The following is a description of a gene set: Genes up-regulated in comparison of primary splenic B cells from wild type mice versus those from BTK knockout mice. species: Homo sapiens Bruton's tyrosine kinase (Btk) is important for B lymphocyte development. To identify genes that are differentially expressed in primary B cells lacking functional Btk, splenocytes from X-linked immunodeficiency (Xid), Btk knockout (KO) and immunocompetent CBA mice, were used in microarrays containing more than genes and expressed sequence tags (ESTs). We found 4515 transcripts expressed in duplicate experiments in all three strains. Out of these, 38 were differentially expressed genes (21 up-regulated >2 fold and 17 down-regulated <-2 fold) between CBA and Btk defective mice. Ten out of these genes were selected and quantitative Real-Time PCR was conducted for validation and further investigation. Real-Time experiments correlated nicely with the microarray data. No definitive phenotypic difference has previously been reported between Xid and Btk KO mice. We found genes, whose expression differed (>2 fold) between the two strains. Moreover, when the genes, which differed between immunocompetent CBA and Btk defective mice were ranked according to fold-increase, the levels in Btk KO mice were significantly more altered. This suggests that the defect in Btk KO mice is more severe and demonstrates that the mutant Btk protein in Xid mice does not generally function as dominant negative form. Human Gene Set: GSE2826_WT_VS_BTK_KO_BCELL_UP from publication Lindvall JM, Blomberg KE, Berglöf A, Yang Q, Smith CI, Islam TC (PMID 15214046), and this is the list of marker genes: RNASEH2A, RIDA, SURF6, UBL3, PLSCR1, PHKG2, EVI2A, WDR6, SRPK3, ACY1, ENDOU, CXCR5, IMP3, CRY2, PRRC2A, PRIM1, RTCB, HERPUD1, ID3, EBI3 (Epstein-Barr virus induced 3), OAT, TRIO, SMYD5, MIIP, IARS2, WIPF1, IL4I1, CALB2, STAG2, INPP5D, WDR20 (NCBI Gene Id 91833), IARS1, CD200, METAP2 (NCBI Gene Id 10988), TIMELESS, ZFR, ACAD9, BCL2A1, DAD1, CYP27B1, ANKRD17, ROBO3, MRPS21, MAF1, FKBP11, BCL6, SAPCD1, VWF, UCK1, PDIA4, RETREG2, EPOP, XRCC1 (X-ray repair cross complementing 1), PRPF31 (NCBI Gene Id 6106), UBLCP1, H2BC13, DNAJC17, SMG5, THUMPD3, MUTYH, COPS4, SGCD, CXXC1, DGKA, NEUROD6, NPEPL1, CEBPZOS, POLR3A, PCP4, NEUROG2, CARD19, MAD2L1, AKAP9, MCM5, ZBTB48, ITPKB, SLC50A1, SLC25A4, RECQL5, MRPS26, MCL1, NAB2, EPRS1, HNRNPC, ICAM2, S100A3, NSMCE1, RAB5B, SLC19A1 (NCBI Gene Id 6573), NEO1, CRAT, PSMB3, USP5, MED20, ZEB1 (zinc finger E-box binding homeobox 1), CAPG, DMWD, EIF3G, BRK1, MRPL48, BTK, COPS6, FAAH, IRF3, MRPL39, MACROH2A1, BID, CSK, ACKR2, NUDT5, MED27, MYG1, SIX6, TCEA3, INVS, ERP44, USP24, NCBP2, USE1, NOTCH4, RELB, IER2, FAM162A, GML, VPS16, RBM26, EPHX1, TFPT (TCF3 fusion partner), GPS1, DHRS3, TBL1XR1, SEC63, POU1F1, LTK, NEUROD4 (neuronal differentiation 4), BMPR1B, KLHDC4, CEP350, TXNDC5, RAP1GAP, LSM2, RPL7L1, CLTA, CASP4, DTX1, RPL41, ACO2, RASIP1, RHOH, PPP3CC, NEK7, ZNF644, LDHA, BCL2, BCAT2, HIVEP2, SLC25A19, CENPC, TYSND1, GTF2A1, B3GNT2, TCF4, MAP3K2 (NCBI Gene Id 51777), MECP2 (NCBI Gene Id 8274), LPP, SPA17, RPP21, MCOLN2, ACADL, SMTN, ME1, ITGA6, CPSF2, ZFPM2, LMO7, BNIP1, APOBEC1, CRLF3, COMMD2, MYO5B, SERPINA12, WIPI2, NCF4, RPL18, SMIM30, HDAC3, DNAJB5, COA6, LAMA1, STRADA, PLEC, RFLNB, CD83, TNFAIP8, SNRPD2, MATN4, RMND1, ESS2, PTPRCAP, LIMK2